The following is a description of a gene set: Mouse Gene Set: GOBP_MUCOCILIARY_CLEARANCE The respiratory system process driven by motile cilia on epithelial cells of the respiratory tract by which mucus and associated inhaled particles and pathogens trapped within it are moved out of the airways. studied in species Mus musculus, and this is the list of marker genes: Ccdc88c, Dnah9, Spef2, Vangl1, Spag16, Spag6l, Cfap221, Ttll1, Stard7, Cfap43, Nek10, Cfap54, Odad4, Drc1